The following is a description of a gene set: studied in species Homo sapiens Human Gene Set: GOBP_POSITIVE_REGULATION_OF_LIPOPOLYSACCHARIDE_MEDIATED_SIGNALING_PATHWAY Any process that activates or increases the frequency, rate or extent of signaling in response to detection of lipopolysaccharide., and this is the list of marker genes: SCIMP, MIF, LY96, TRAF6 (TNF receptor associated factor 6), PRKCA, SASH1 (SAM and SH3 domain containing 1), LY86, BMP6, CD180, PTPN11, CD14